Given this list of marker genes Pygm, Prps2, Pygl, H1f4, Fbp1, Ak8, Prps1, Cfap45, Acss1, Pfkm, Akap7, Aprt, Prkag2, Oxgr1, Cyb5r3, Mpped2, Prkag1, Prkag3, here is a description of the gene set: Mouse Gene Set: GOMF_AMP_BINDING studied in species Mus musculus Binding to AMP, adenosine monophosphate.